The following is a description of a gene set: Human Gene Set: GOMF_MINUS_END_DIRECTED_MICROTUBULE_MOTOR_ACTIVITY studied in species Homo sapiens A motor activity that generates movement along a microtubule toward the minus end, driven by ATP hydrolysis., and this is the list of marker genes: DNAH11, DYNC1H1, DNAH8, DNAH1, DNAH3, DNAH2, DNAH12 (NCBI Gene Id 8679), DNAH9, KIF25, DNAH14, DNHD1, DNAH7, DYNC2H1, DNAH17, DNAH10, DNAH6, DNAH5